Given this list of marker genes Gstp1, Cat, Itga2, Lep, Sod2, Il1a, here is a description of the gene set: Any process that results in a change in state or activity of a cell or an organism (in terms of movement, secretion, enzyme production, gene expression, etc.) as a result of an L-ascorbic acid (vitamin C) stimulus. Mouse Gene Set: GOBP_RESPONSE_TO_L_ASCORBIC_ACID species: Mus musculus